The following is a description of a gene set: studied in species Homo sapiens from publication Chen Y, Wang X (PMID 31504780) Human Gene Set: MIR1226_5P Genes predicted to be targets of miRBase v22 microRNA hsa-miR-1226-5p in miRDB v6.0 with MirTarget v4 prediction scores > 80 (high confidence targets)., and this is the list of marker genes: TTPA, NUDT16L1, PAG1 (NCBI Gene Id 55824), ZNF275, MBOAT2, CMTM4, FNBP1, SORT1, RCAN3, CA5B, ITGA10, CCAR2, SCN3B, NLRP5, BMPER, S100A10, TP53TG3, GABPB1 (GA binding protein transcription factor subunit beta 1), JAK1, SNX20, FKTN, ARHGAP40, OGT, LUZP1, SIX1, USP38 (ubiquitin specific peptidase 38), PEG10, SLC24A4, RAB21, ICOS, FAM216B, KCNS1, MPZ, RPGR (NCBI Gene Id 6110), CELF2, KCNB1, C2orf88, ADCY6, OR2A4, GADD45A, CMIP, ZSCAN32, ARID3B, DLX3, TP53TG3B, TP53TG3D, RELL1, IKZF1, C15orf61, SHROOM2, SUMO1, MLLT11